The following is a description of a gene set: Human Gene Set: HP_ASPIRATION_PNEUMONIA Aspiration pneumonia Pneumonia due to the aspiration (breathing in) of food, liquid, or gastric contents into the upper respiratory tract. studied in species Homo sapiens, and this is the list of marker genes: ASAH1, MYL2, CRIPTO, ACTA1, FGF8, TPM2, STIL, ARID1B, MID1, ATP6V1B2, PAFAH1B1, KDM6A, SP110, GLI2, NADK2, DLL1, SAMD9, GRHL3, SDHD (succinate dehydrogenase complex subunit D), PURA, SMC1A, PIK3CD, GAS1, SLC25A24, ARID2, IGBP1, ARID1A, SELENON, EPM2A, TGIF1, GLB1, TAF1, HLA-DQA1, NTRK1, MYO1H, PIGA, PIGN, SMARCC2, NOS1, STAG2, TBC1D24, COL4A6, PTCH1, LRIF1, SMARCE1, PLA2G6, PANK2, KNSTRN, HACD1, ZIC2, RILPL1, CDON, SNAP29, SOX11, FIG4, ATP6V0A1, NDUFA6, LONP1, PLCH1, AFF4, SOX4, LMNB1, DPF2, NFIX, SMARCA4 (SWI/SNF related, matrix associated, actin dependent regulator of chromatin, subfamily a, member 4), SMARCD1, ITGA7, TIMM8A, KIAA0586, NHLRC1, MAP3K20, UBB, KMT2D, FGFR1, SIX3, HLA-DQB1 (NCBI Gene Id 7924), LRP12 (NCBI Gene Id 80002), PTCD3, GIPC1, SHH, TPM3, CSPP1, PMM2, NOTCH2NLC, NODAL, MARS2, FOXH1, CRLF1, KAT6A, DISP1, PDHA1, TFG, COL4A5, SMARCB1, GBA1